Given this list of marker genes IP6K1 (inositol hexakisphosphate kinase 1), IP6K2, IPPK, IPMK (NCBI Gene Id 253430), here is a description of the gene set: Reactome Pathway: Synthesis of IPs in the nucleus Within the nucleus, inositol polyphosphate multikinase (IPMK), inositol-pentakisphosphate 2-kinase (IPPK), inositol hexakisphosphate kinase 1 (IP6K1) and 2 (IP6K2) produce IP5, IP6, IP7, and IP8 inositol phosphate molecules (Irvine & Schell 2001, Alcazar-Romain & Wente 2008, York 2006, Monserrate and York 2010, Nalaskowski et al. 2002, Chang et al. 2002, Chang & Majerus 2006, Saiardi et al. 2001, Saiardi et al. 2000, Draskovic et al. 2008, Mulugu et al. 2007). part of: Inositol phosphate metabolism species: Homo sapiens